Given this list of marker genes MMAA, MMUT, here is a description of the gene set: studied in species Homo sapiens part of: Diseases of mitochondrial beta oxidation Reactome Pathway: Diseases of propionyl-CoA catabolism